The following is a description of a gene set: Mouse Gene Set: GOBP_REGULATION_OF_TRANSCRIPTION_REGULATORY_REGION_DNA_BINDING Any process that modulates the frequency, rate or extent of transcription regulatory region DNA binding. studied in species Mus musculus, and this is the list of marker genes: Zc4h2, Gata3, Id2, Hand1, Dot1l, Lif, Mad2l2, Sox11, Niban2, Hey2, Rb1, Fbxw7, Gata1, Traf6, H1f0, Zbtb7c, Hand2, Rnf220, Zbtb7a, Zmpste24, Lhx2, Psen1, Neurod1, Pou4f1, Igf1, Park7, Ifng, Nsd1, Dazap2, Ddrgk1, Lamtor5, Pou4f2, Twist1, Mir744, Trim6, Hcfc2, Msx2, Pax6, Msx1, Foxc1